Given this list of marker genes TELO2, CTDSPL (CTD small phosphatase like), CD99, ACAP1, ETS1, KRT5, PDAP1, MPZL2, HDGF, NOP53, TLE5, LY6E, GIPC1, SLC35B2, GET4, BCAP31, RPL39L, PFN1, HMG20B, BCL2L15, HSPE1, CCND1, SYK, TPRA1, ACTN4 (NCBI Gene Id 81), MTA1, ATP6V0A1, FLOT2, DEPDC5, IFITM1, ADRA2C (NCBI Gene Id 152), EIF5A, CYB5R3, CAPN1, TGM2, SCAP, L1CAM, ABCC1, PRKCSH, PCDH9, SCN5A, S100A3, MMP14, POLR2A (RNA polymerase II subunit A), ALG3, HNRNPUL1, FBRS (NCBI Gene Id 8734), UBA1, NSMF, GJB1, SLC1A5, SORBS3, MAP3K11, SH2B2, DOK1 (docking protein 1), RAB1B, SF3A1, LMNA, SEC61A1, HNRNPA0, GNA12, ADSS2, HDAC3, PCNA, AGRN, CPSF4, ARHGDIA, POLR2E, PKP3, KRT7, IGF2, here is a description of the gene set: from publication Lin YM, Ono K, Satoh S, Ishiguro H, Fujita M, Miwa N, Tanaka T, Tsunoda T, Yang KC, Nakamura Y, Furukawa Y (PMID 11522623) Genes up-regulated by forced expression of APC in the APC-deficient SW480 cell line (colon cancer). Human Gene Set: LIN_APC_TARGETS studied in species Homo sapiens To elucidate the molecular mechanism of colorectal carcinogenesis, we have been attempting to isolate genes involved in the beta-catenin/T-cell factor pathway. In the experiments reported here, analysis by cDNA microarray indicated that AF17, a fusion partner of the MLL gene in acute leukemias with t(11;17)(q23;q21), was transactivated according to accumulation of beta-catenin. Expression of AF17 was significantly enhanced in 8 of the 12 colorectal cancer tissues examined. Introduction of a plasmid designed to express AF17 stimulated growth of NIH3T3 cells, and fluorescence-activated cell sorter analysis indicated that the AF17 regulation of cell-cycle progression was occurring mainly at the G(2)-M transition. Our results suggest that the AF17 gene product is likely to be involved in the beta-catenin-T-cell factor/lymphoid enhancer factor signaling pathway and to function as a growth-promoting, oncogenic protein. These findings should aid development of new strategies for diagnosis, treatment, and prevention of colon cancers and acute leukemias by clarifying the pathogenesis of these conditions.